The following is a description of a gene set: Genes down-regulated in monocytes: CD16- versus CD16+. Human Gene Set: GSE34515_CD16_NEG_VS_POS_MONOCYTE_DN species: Homo sapiens from publication Frankenberger M, Hofer TP, Marei A, Dayyani F, Schewe S, Strasser C, Aldraihim A, Stanzel F, Lang R, Hoffmann R, Prazeres da Costa O, Buch T, Ziegler-Heitbrock L (PMID 22531920) In this study gene expression of human blood classical monocytes (CD14++CD16-), CD16 positive monocytes (consisting of non-classical CD14+16++ and intermediate CD14++CD16+ monocytes) and CD1c+ CD19- dendritic cells from healthy subjects were investigated., and this is the list of marker genes: TADA1, CAVIN3, EFCAB2, PRKAR2B, EVA1B, TOP1MT, CYB5R1, CELF6, LMNA, EXOC4, MVD, RUNX2, TMED10, H2AC11, RAB4B, PTGFRN, CEP43, SEPTIN6, DST, IRAK1BP1, PALD1, CTTNBP2NL (NCBI Gene Id 55917), AP2S1, CD200R1, HADH, EP400P1, CIITA, CMTM3, EEF1AKMT1, PRKCA, CREB3, BOLA3, FXYD6, IRF4, PPIB, OSTC, PKIG, RAB13, CCDC88A, PPP2R1B, SNRPF, MAP7, ZNF439, USP13, CD38, CCDC106, OPN3, RPL13, GPX7, ANTXR2, BCL7A, SEC61B, BTN2A3P, ARL2, IGFBP7 (insulin like growth factor binding protein 7), SPINT2, ARMCX1, PCNX2, SEC61A2, THEM4, PDE7B, HLA-DPB2, SCFD2 (NCBI Gene Id 152579), SPINDOC, EEF1E1, LTC4S, RACK1, MYO1E, MRPS28, SEC22C, VAMP1, ADCY3, SKIC8, DTX4, CCNB1IP1, DARS1, POLR2E, CD1E, GOLPH3L, NDUFS8, CLK2, LINC00205, TCEAL1, TCEAL3, EIF4G3, JHY, TMEM205, SPIB, LRRC8C, RPLP2, NME8, GAS6, EIF3K, ITGB7, TULP3, CISD1, LAMTOR1, RAN, FAAP20, TGIF2, RIMKLB, LILRA4, TM7SF2, RPL3, TNFSF8, DDIT4, P2RY6, CTPS1, PLA2G12A, SLC9A7, ACP6, ASF1A (anti-silencing function 1A histone chaperone), TSPAN33, TMEM223, GSTZ1, FABP5, GINS1, TMEM14A, LGMN, ECI2, SEPHS1, ADCK1, POLR1C, ALDH2, ETHE1, NIPA1, CLCN5, RPS18, RPL22, AHR, MRPS15, ATP5MC1, ZNF571, PACC1, GTF2H4, RRS1, HSPD1, EMD, PPP1R16A, C1QBP, BCL7C, SNRPA, ARFIP2, PCLAF, CHD1L, HEATR6, SYNGR3, SLC43A1 (NCBI Gene Id 8501), SPIN1, SYNJ2BP, PXDC1, DAB2, ILF2, POGLUT3, ATL2 (atlastin GTPase 2), ST3GAL4, WDR54, SELL, LYRM4, SNAI3, SFPQ, TRUB2, RPS4Y1, C10orf95-AS1, MTFMT, TP53I13, RPS5, PUM3, UFC1, MTX1, TMSB15B, MRPL33, PON2, CAMTA1, OXCT1, COMT, TMEM270, ATPAF2, PARP2, NCBP3, GRAMD2B, SSBP1 (NCBI Gene Id 6742), RPL18, F13A1, GNA15, FASTKD2, RBMS2, MRI1, GHRL, TRAF4, SLC7A5, MS4A6A, IGFLR1, AGXT2, SDR39U1, PDCD2L, CRABP1, COQ4, MAP4K1